Given this list of marker genes FBXL7, GPC3, MBOAT2, CNOT1, ARID4A, OTUD7B, SUV39H2, SCARA3, PHF12, TMED10, LCOR, TSC22D2, CHTOP, SUPT16H (NCBI Gene Id 6831), NEUROD1, CDC14A, EPC1, POU2F1, POLA1, BCLAF1, CEP135, NKIRAS2, ADK, RAB1A, EN1, SAFB, PRDM10, PPP2R2A, DLEU2, PPAT, NPAT, ZNF143, PPP1R15B, CSE1L, DNAJC7, KAT7, RAC1, ATM, TRA2A, DLEU1, YARS1, UBE2K, STAG2 (NCBI Gene Id 10735), PCYT2, RBMX, NCAPH2, MCM7, CD4, HOXC4, GPBP1, PAICS, COL27A1, ZBED5, PSPC1, IFT80, ATOH1, FAM193B, PDS5B, HOXC6, SMC4, USP11, AP4M1, LUC7L3, LMF2, KCNK9, TARDBP, SRSF2, HOXA2, SRSF1, PITX1, GABPB2, here is a description of the gene set: Comprehensive identification of all functional elements encoded in the human genome is a fundamental need in biomedical research. Here, we present a comparative analysis of the human, mouse, rat and dog genomes to create a systematic catalogue of common regulatory motifs in promoters and 3' untranslated regions (3' UTRs). The promoter analysis yields 174 candidate motifs, including most previously known transcription-factor binding sites and 105 new motifs. The 3'-UTR analysis yields 106 motifs likely to be involved in post-transcriptional regulation. Nearly one-half are associated with microRNAs (miRNAs), leading to the discovery of many new miRNA genes and their likely target genes. Our results suggest that previous estimates of the number of human miRNA genes were low, and that miRNAs regulate at least 20% of human genes. The overall results provide a systematic view of gene regulation in the human, which will be refined as additional mammalian genomes become available. from publication Xie X, Lu J, Kulbokas EJ, Golub TR, Mootha V, Lindblad-Toh K, Lander ES, Kellis M (PMID 15735639) Genes having at least one occurrence of the highly conserved motif M164 GCGSCMNTTT in the regions spanning 4 kb centered on their transcription starting sites. The motif does not match any known transcription factor binding site. Human Gene Set: GCGSCMNTTT_UNKNOWN species: Homo sapiens